The following is a description of a gene set: The chemical reactions and pathways resulting in the formation of isopentenyl diphosphate, an isomer of dimethylallyl diphosphate and the key precursor of all isoprenoids. species: Homo sapiens Human Gene Set: GOBP_ISOPENTENYL_DIPHOSPHATE_BIOSYNTHETIC_PROCESS, and this is the list of marker genes: MVD, IDI1, PMVK, MVK, IDI2